The following is a description of a gene set: Human Gene Set: ATF_B Genes having at least one occurrence of the motif NTGACGTCANYS in the regions spanning 4 kb centered on their transcription starting sites. This matches the transcription factor binding site V$ATF_B (v7.4 TRANSFAC). studied in species Homo sapiens, and this is the list of marker genes: RBKS, AKIRIN1, VIP, MAFF, RBP5, TSPAN7, DNTTIP1, NR2E1, PAFAH1B1, PACRGL, CYLD, HS3ST2, CCNA2, SST, SULT4A1, GPR3, GTF3C1, EPB41, TSC22D2, PNRC1, PITX2, PAK1, SLC25A25, MITF, TEX14, RPRD1A, DCTN1, PPM1A, SUV39H2, SPRED2, SCG2, CCDC148, CBX8, RAB25, NEUROD6, CD2AP, RAB24, FLT1, APPBP2, KCNF1, PHACTR3, CRH, FOSB, FOXD3, IKBKB, YWHAZ, ZIM2, ATP6V0C (NCBI Gene Id 527), CAMK2D, PER1, ID1, LDHA, LMCD1, PPP1R15A, VPS37B, SLC18A2, TRAP1, WFDC3, LGR5, HOXD8, CALM2, KCTD8, MBNL1, IRX4, ZFAND2B, GRP, GNB4, CREM, ABCE1, PARD6A, DDX19A, RAI1, ZNF593, CLDN6, PRELID1, TH, MCAM, PNMA6A, SGIP1, PKP4 (plakophilin 4), ATL2, ING4, ELAVL1, CHGB, SNAP25, DEPDC4, HS3ST3A1, CTC1, ANAPC10, RNF44, TIPRL, HAS1, TRAPPC1, CYSTM1, ELOVL5, CLSTN3, THADA, CDK2AP2, TACR1 (tachykinin receptor 1), FAM174A, PFAS, TRAF4, AGPAT4, SCAMP5, ADCY8, PLCD3, NEK1, JUND, FOS, PDLIM3, NUBPL, SIDT2, SEMA4C, LTBP1, SPAG9, UCN, OSR1, YTHDC2, MAP3K13, ZNF367, RUNDC3A, PPP2R2A, HHIP, ADAP1, HSP90AB1, PEG3, PPARGC1A, NOL4, DUSP1, OSBPL9 (NCBI Gene Id 79638), DAAM2, GPM6B, FAM131A, RCAN1, AHI1, SIK1, ABHD16A, EEF2, TMEM39A, CDX4, RUSC1-AS1, RCE1 (NCBI Gene Id 9986), GEM, PNMA3, C11orf87, UBE2B (ubiquitin conjugating enzyme E2 B), TAOK2, MBNL2, FGF6, UBE2H, AREG, CNTROB (NCBI Gene Id 116840), RUSC1, AFF4, CCN4, TNFAIP1, PRR3, GPBP1, MAP1LC3A, PTPRU, RING1, RIPOR1, ATG5 (autophagy related 5), AVPI1, PAK3, IRX6, NDUFB2, TMEM59L, ZNF576, VGF, IRF2BPL, CHMP1B, SRRM4, BABAM2, IFT20, PDP1, RAD51C, ZBTB11, NUP42, NCALD, EPHA2, OGDH, GNL1, MYL6, HOXC10, C1orf35, CMSS1, RNF7, DIO2, ASPHD1, MAPK10